Given this list of marker genes L3MBTL2, MBTD1, KDM4A, L3MBTL1, TP53BP1, TTLL12, here is a description of the gene set: species: Homo sapiens A histone reader that recognizes a histone H4 dimethylated at lysine 20. Human Gene Set: GOMF_HISTONE_H4K20ME2_READER_ACTIVITY